Given this list of marker genes MKKS, DIXDC1, PPM1E, YME1L1 (YME1 like 1 ATPase), BUB1, MIR138-1, DRD3, TESK1, HNRNPA2B1 (NCBI Gene Id 3181), SMG5 (SMG5 nonsense mediated mRNA decay factor), SYNPO2, MAP6, CLSTN3, C15orf62, DNM1L, TBC1D13, ODF2, CHMP7, HSP90AA1, PGAM5, CDC6, PLA2G5, CELSR1, KLHL22, ACAA2, KANK4, PLAUR, PPP3CB, TACC3, LILRB2, PRELID1, UPF1, MAP9, LIMCH1, PARL, BORA, SLF2, SRC, PEAK3, CENPV, PKD1, TPR, NBDY, NUF2 (NCBI Gene Id 83540), FGF8, ATRX, BCAS3, TPPP, TMED9, MYCBP2, CEP135 (centrosomal protein 135), GRID2, VPS35, TTK, HUWE1, TMEM39A, BCL2L11, POT1, GCLC, ARF4, MAPK9, TMOD2, CUL7, EML3, NCK1, ATMIN, TBC1D24, SPTA1, SMARCA2, PHF23, ZWINT, ARPC5, EVI5, NEK6, DCTN1, SEC16A (SEC16 homolog A, endoplasmic reticulum export factor), ACTB (actin beta), HAUS1, PDE4DIP, MAVS, ALMS1, WNT4, KAT2A, RAC1, FBXO4, BRD7, GIT1, MIR149, ZDHHC6, INPP5J, WASHC1, PFDN2, SWAP70, TMSB4X, RND3, TTBK2, BID, TAC1, NFRKB, SPECC1L, PTGES3, SMG6, SURF4, SKA3, ANAPC11, SMARCC2, USP7, PHLDB1, EFNA5, CALCOCO2, F11R, CIT, HIP1R, CDC42EP5, MSX1, ARHGAP44, TUBB4A, SETMAR, SDC4, SIRT7, TGFA, MTBP, KNL1, MTCH2, HAUS2, PIKFYVE, PSMA8, CBLN1, ARHGEF15, STX5, CNOT1, NCKAP1L, MTM1, SPTBN1, MAPK1, PRKCQ, SCFD1, CUL9, DAZL, PYCARD, SMC4, CCL26, SLC39A12, MECP2, PAN2, FZD10, CHMP4B, CHEK1, CCT6A (NCBI Gene Id 908), PPM1F, MDM1, NCAPH2, FGFR1, TENM1, KIF9, ARAP2, MAK, CFL2, PARP1, CSF3, HCLS1, TNKS2, NANOS2, MSN, LIG4, CDK2AP2, CDK10 (cyclin dependent kinase 10), ERC2, SPAG5, PISD, XRCC1, CTC1, ODF2L, CAPZA2, SVIL, PIK3R1, HDAC8, SPHK1, RHOC, TFEB, MYO5A, SPC24, SMARCD1, HASPIN, ARAP1, LMOD1, PDCD6IP, TRPM2, LCMT1, DMRT1, SLAIN1, DYRK1A, DVL2, CAPZA1, S100A8, DIAPH3, NCAPD2, CYFIP1, CAPN2, TBC1D9B, ULK1, OPA1, WEE2, SHANK3, RND1, BAIAP2, BIN1, SYT4, FSHR, CLU, GAS2L1 (growth arrest specific 2 like 1), MYOC, MIR214, MCOLN1, JAM3, ZMYND10, NRP1, ESAM, KATNB1, CHMP1B, ARL2, ACTR5, CORO1A, CYLD, WASHC2A, MOS, CEP97, ARHGEF10, SPAST, PLK4, EHMT2, BMERB1, AURKA, SMARCB1, BBOF1, PIF1, GAS2L2, OBSL1, LATS1, ARPC3, LRFN1, PXN, FCHSD1, PJVK, YY1, NSMCE3, KCTD17, CDK5R1, SIGLEC15, LRFN4, NCK2, ANXA2, CCT8, PRKN, WRAP73, TERF1, BCL7A, BRAF, GNAI1, ARF1, CAMSAP1, TMEM14A (transmembrane protein 14A), PSRC1, GPR143, RBSN, MGARP, SIRT6 (NCBI Gene Id 51548), TBC1D17, RHOD (NCBI Gene Id 29984), PRMT6, NUMA1, IER3, SIRT2, SNX4, ARHGAP28, DYNC1H1, SAR1B, OCLN, CLEC16A, GAP43, MAPK15, PRKCD, RAPGEF3, SSH1, IQCJ-SCHIP1, MAP4, VASP, RALA, ARHGEF19, PKIB (NCBI Gene Id 5570), LIMK2, CCT2, BAG4, SFPQ, BRK1, CEP76, TMEM33, CDC42, MAPRE1, CUL3, TFPT, SPTB, ANAPC1, CHMP5, ABL1, RCC1, SPC25, OSBP, CHMP4BP1, CCSAP, NABP2, SPATA4, ARAP3, SDC1, ACTL6B, CLASP1, IRGM, SEPTIN7, TMEFF2, PTK2, SMARCD2, CPLX3, PRDM9, CAPZA3, CTNNB1, ACTL6A, PICK1, SYT11, FBXO5, BBC3, MAPK3, CDCA8, PRKAA2, PRUNE1, NGEF, BRCA1, RAB5A, USP44, TMEM135, STMN3, ANAPC15, GHITM, RUVBL1, ZNRF2, DDHD2, MSTO1 (misato mitochondrial distribution and morphology regulator 1), TEX14, SQSTM1, RBM14, RAB1B, DIAPH1, STMN2, PIN1 (NCBI Gene Id 5300), CCL21, CDKN1B, PLXNB1 (plexin B1), BMP10, TERF2IP, CD2AP, FSCN1, BCL7B, EP300, INO80, APC, RAD51AP1, PINX1, PLK1, SMARCA4, IQGAP2, HAUS8 (NCBI Gene Id 93323), NME7, MIEF2, WDPCP, TOM1, SPTAN1, WAPL, PKMYT1, TBCD, EPHA1, OOEP, TGFB2, ODAD3, SMARCA5, MPHOSPH9, ANAPC5, NCAPG2, TBC1D8, ADD1, CTCF, RGCC, FUZ, SPEF1, CDK5R2, GEN1, ITGB1BP1, HAUS7, EPGN, VILL, CYRIB, MEIOSIN, ATG2A, WRAP53, BUB3, CHMP1A, WASF1, ODAM, NAA20, CAPN10, CDC16, SFRP1, MARK2, TBC1D25, YLPM1, COTL1, PRKAA1, AURKAIP1, MYC, PREB, DYNC1LI1, CCNF, PAN3, CCL24 (NCBI Gene Id 6369), CDCA2, LRRTM2, PML, NSMCE1, DOC2A, PINK1, SMARCC1, BAX, BIRC5, NUBP1, CKAP5, NAV3, SLX1A, ECT2, PHF10, TBC1D10C, INCENP, HSF1, BICD1, TMEM102, SMC5, NAT10, ATM, STN1, CDKL1, PAFAH1B1, SYT5 (synaptotagmin 5), SAR1A, RMI2, BMP7, CENATAC, FLNA, ARF6, VAT1, SHCBP1L, BNIP3, NEK2, OR2A4, NOL3, ATG12, TEN1, SIRT1, CCDC88A, TRIM27, FES, RAB7A, INF2, MAP3K20, TOM1L2, CLTC, PID1, ARHGEF10L, SCARB2, CCT3, SNX18, WASF3, VPS4B, STAU2, RHPN1, SLC9A1, CCP110, SHANK1, MOAP1, GSK3B, STAT2, ADD2, ROCK1, SEC22B, EVI5L (ecotropic viral integration site 5 like), TNF, EML2, CORO2B, SMPD3, ZW10, SLC2A4, WNT5A, SYNPO, ATP5IF1 (ATP synthase inhibitory factor subunit 1), TBC1D10B, WDR1, ABI2, TBC1D5, CPLX2, BCL7C, MMP9 (NCBI Gene Id 4318), XRCC5, CPLANE2 (NCBI Gene Id 79363), PLEK, ASB2, PIP4K2B, ENDOG, UBQLN4, BCL2L1, KATNBL1, RPH3AL, ANKRD53, WDR47, CDC23 (NCBI Gene Id 8697), SYNPO2L, TACSTD2, SKA2, RPS3, HDAC6, RHOBTB2, CD47, NF2, LUZP1, USP6NL (USP6 N-terminal like), SLC25A6, DVL3, BST1, CTTN, CAPN6, STX18, TBC1D14, CDH5 (cadherin 5), MYLK3, NPM2, MIR1-1, LPAR1, CCT7, RAC2, TP53, HAUS6, HIGD1A, CDK5RAP2, GSK3A, MNS1, SYNJ1, SNCA, CFL1, GPR3, ANXA1 (annexin A1), WASHC5, GPR65, S1PR1, SLC35F6, CAMSAP2, SPDL1, SLC30A9, TPM1 (NCBI Gene Id 7168), RUVBL2, TACR1, PLEKHH2, SNX7, AXIN2, RDX, TBC1D10A, POC1B, GRN (NCBI Gene Id 2896), NSMCE2, NUPR1 (NCBI Gene Id 26471), BAIAP2L2, SEPTIN9, GPX1, EDN1, ACTN2, INS, CDC20, ATXN7, PIP4K2A, STIL, ATG3, RHOA, CAV2, NSMCE4A, TRIM54, SMCR8, MAP2, KANK1, PSMG2, PPP2CA, PTK2B, DZIP1, GMFB, TMOD1, HAUS5, TWF1, IL5, STAM, MARCHF5, NFE2L1, KIF18A, FERMT2, SYT3, TAL1, TRIM32, HRAS, RAE1, EPHA3, INO80B, PRRT2, PHIP, RPH3A (rabphilin 3A), DMTN, CXCL12, CHEK2, STMN1, EPHA5, IK, SEMA5A, PRMT5, STRA8, RAB3A, RABEP2, ANKRD27, CALR, MIEF1, CDK2, CAPZB, RAB3GAP1, S100A10, RAC3, ITGB3, RAD1, INTU, MAPRE3, PLEKHG2, STMN4, CPLX1, NAA80, TMOD4, PBRM1, SAXO1, TAPT1, CCR7, SMIM22, TBC1D3, CNTROB (NCBI Gene Id 116840), ACTG1, BIK, CARMIL1, TGFB1 (transforming growth factor beta 1), HNRNPU, HRK, PSMD10, HAUS4, CEP120, CROCC, MAD1L1, ANAPC2, FNIP1, BAK1, INPP5K, MCIDAS, PLD6, DAAM2, VIL1, IFT140, TNFSF10, S100A9, TSC1, MAPT, CCN2, ARID1A, TOGARAM2, GNL3, EVL, RTEL1, ARHGEF18, MCPH1, INO80D, TFRC, PAK3, TMEM106B, HAX1, ARHGEF16, DCN, KDR, MAP1A, C11orf65, MCRS1, AP1AR, CCDC8, MSX2, CCNB1, MAD2L2, NDC80, KIF20B, NVL, C2CD5, RNF186, LRRC4B, NEXN, BAZ1B, LIMA1, PREX1, GPM6B, GRIK5, SYT9, DCP2, CAPG, BICD2, DLG1, CNOT2, ADCK1, RHOQ, AKAP13, CCT4, CORO1B, MTOR, CEP70, FYCO1, TBC1D7, SSBP1, CNOT6, RNH1, CD28, SMC6, DDHD1, CSF1R, WDR44, PRAP1, SYT13, RAB11FIP3, RPS6KA2, HSPA1B, WASHC4, NEK7, MARK4, ABITRAM, TOM1L1, TCP1, CHMP4C, MID1, BAIAP2L1, TTC8, SMAD4, CDK1, FEZ2, FBXO43, HNRNPD, ARHGAP35, MAP2K2, TBC1D2, SMARCD3, EPS8, SLIT2 (NCBI Gene Id 9353), LRRK2, NAA10, MYO19, ATR, WASH3P, GSN, PRKD1, CHFR, BECN1, IFT20, PLCB1, MAPRE2, TOGARAM1, ARFIP2, RAB33B, SPTBN2, RAB3GAP2, CRIPT, UBE2C, CYRIA, TRPV4, NUP62, PDGFRA, KANK2, SPICE1, KIRREL1, WAS (WASP actin nucleation promoting factor), GBA2, GNL3L, MKI67, GPER1, FSD1, NPHS1, SDCBP, KIF24, TBC1D15, PAK1, CDKL5, TSG101, TRIM36, INO80C, RNF4, TBC1D30, HCK, MTSS1, FIS1, TJP1, BAD, CLIC4, FKBP4, MID1IP1, ARHGEF2, HGF, DLGAP5, VANGL2, LMOD2, CDC42EP3, MIR335, SYNE2 (spectrin repeat containing nuclear envelope protein 2), FGF13, MYO3B, MFF (mitochondrial fission factor), TBC1D20, LRP5 (LDL receptor related protein 5), FCHSD2 (NCBI Gene Id 9873), ZNF205, MPV17L, GRHL3, SPIRE1 (spire type actin nucleation factor 1), RGS4, CKAP2, BMP4 (bone morphogenetic protein 4), CENPE, HNRNPA1, CAV3, CAPRIN1, WASHC3, MTMR3, SPTBN5, PRKCE, CTNNA2 (catenin alpha 2), SDCCAG8, IL1RAP, BTC, CARMIL2, GOLPH3, DCDC2, PRICKLE1, CHMP2A, NCAPH, PPP2CB, TAOK1 (NCBI Gene Id 80214), NAF1, RHOG, SSH3, RICTOR, F2RL1, ARHGEF26, SNX30, LRSAM1, INO80E, TAOK2, SLC25A31, PIWIL2, MARCHF7, WASHC2C, ADAMTS16, ARPC2, ELN, RUBCN, PTGER4, ZNRF1, ARHGAP18, DUSP1, CNOT6L, KAT2B (NCBI Gene Id 8850), UVRAG, PIP4K2C, PAK2, PPIF, DPF3, GRB2, FEZ1, CEP295NL, H3-3B, SLC30A1, FEN1, MAD2L1, MIR21, IFI6, SLC25A4, MLLT11 (MLLT11 transcription factor 7 cofactor), ATAT1, PARN, PTPRS, IL1A, CDH2, CDC42EP4, NEDD9, CHMP3, TBC1D19, NES, MAGEL2, PDXP, KNTC1, TNKS, SLC25A5, FBXW5, ANKRD23, MYO3A, TGFBR1, SGSM3, AKT1, TBC1D16 (TBC1 domain family member 16), TRIM37, PPP1R35, LIMK1, PDGFRB, LNPK, EID3, CDC27, AKAP9, MAP1S, FZR1, RAP1GDS1, CCDC15, AURKB, IGF1, MAD2L1BP, SERPINF2, HNRNPC, EREG, KANK3 (KN motif and ankyrin repeat domains 3), TECPR1, MYADM, PPARG, L3MBTL1, SNX9, MLST8, AVIL, DYNC2LI1, PFN1, SH2B1, ZNF207, TERF2, CARMIL3, TCHP, RHOBTB1, SMARCE1, HECW2, BST2, SMAD3, RND2, MAP6D1, TENT4B, ERCC4, NCAPG, FLCN, ZWILCH, MAP3K4, STYXL1, GMFG, CENPF, ANAPC7, PHLDB2 (pleckstrin homology like domain family B member 2), DPF2, DPF1, UCHL5, CYFIP2, PDGFA, CAMSAP3, WHAMM, MACROH2A1, BMF, TBC1D21 (TBC1 domain family member 21), ARFGEF1, SH3BP1, RHOF, DOC2B, SCIN, ARL6IP1, KAT5, LIF, STMND1, RB1, TBC1D22A, STOX1, GDI2, ENTR1, ADRB2 (NCBI Gene Id 154), PDE2A, DNAI3, RIPOR2, HSPA1A, PFN2, RABGAP1 (NCBI Gene Id 23637), HOXA13, PFN3 (NCBI Gene Id 345456, profilin 3), TMOD3, UBAP2L, SYT8, FXN, BBS4, TBC1D1, ARID1B, ARHGEF5, SYT2, RIOK2, ZEB2 (NCBI Gene Id 9839), TBC1D4, SLAMF1, P2RX7, XRCC3, SYT7, WASF2, HAP1, CPLX4, SLX4, PLK2, RASA1, FAM107A, KIF21A, MAP1B, HTT, CHMP6, DLC1, LMOD3, SYDE1, ATP13A2, PLXNA3, NOTO, SENP6, SLC4A2, ARFIP1 (NCBI Gene Id 27236), CCL11, SKA1 (NCBI Gene Id 220134), WDR45, CGNL1, ERCC1, EPHB2, DHX36, EFNB1, SSH2, PRP4K, RHOT1, C9orf72, ASAP3, DYNLT2B, INSR, CDC42EP2, RAD50, TRAPPC12, CEP295, USP10, MET, XRN1, VPS11, MICU1, GPSM2, UBQLN2, ATG5, TRIOBP, PDGFB, LMNA, CDC42EP1, PDE3A, ELAPOR1, DAPK3, RAD21 (NCBI Gene Id 5885), TRAF3IP1, SMC2, CLASP2, FLII, SASS6, MRE11 (MRE11 homolog, double strand break repair nuclease), CHMP4A, PMAIP1, ARHGEF9, CCT5, ABI3, APOA1, RALB, ABL2, PARP3, ARHGAP40, C10orf90, MIR20A, TRIP13 (NCBI Gene Id 9319), CSF2, ARID2 (NCBI Gene Id 57676), TBC1D22B, TINF2, APC2, MCU, TGFB3, ARHGAP6, PATL2, ACD, STXBP1, HAUS3, FER, MAP2K1, BUB1B, DRG1, WASH6P, TBC1D12, MAP2K7, RP1, CDC25C, BOK, FZD9, SMG1, IL1B, FRMD7, TBC1D2B, PIK3CA, PIK3R2, ARHGAP17, RALBP1, ADD3, ARMH3, LCP1, CRACD, YAP1, RHPN2P1, SH3GLB1, OAZ3, CLN3, WIPI1, SPTBN4, ACTR8, TRIAP1, NEB, TREX1, MAPKAPK5, H3-3A, MUL1, LAPTM4B, DSTN (NCBI Gene Id 11034), CHMP2B, PLSCR3, IFT88, IGF2, CLIP3, MTPN, SORBS3, ARPIN, PNKP, OMA1, CHCHD10, CLIP1, HDGFL3, FAM162A, SYT1, ANK1, CCDC88C, NUSAP1, HRG, AMOT, TWF2 (NCBI Gene Id 11344), SIVA1, UBE2B, CIB1, HORMAD1, NPR2, PPFIA1, ROCK2, ANAPC4, CASKIN1 (NCBI Gene Id 57524), CX3CL1, CRK, ARPC5L, PROX1, INPPL1, RAB11A, EHD3, TMEM67, ARHGEF7, DKC1, NCAPD3, LMAN1, EZR, EDN3, XIRP2, CENPJ, EGF, KLF4, PPP1R10, RHPN2, TMSB4Y, LRP1, WNT3A, NCKAP1, NPM1, TPX2, FHOD1, NBN, EXOSC10, SLAIN2, ALOX15, SLX1B, NME6, RNF5, ESPL1, SLF1, ZMYND8, PTPRD, DDX11, here is a description of the gene set: Human Gene Set: GOBP_REGULATION_OF_ORGANELLE_ORGANIZATION Any process that modulates the frequency, rate or extent of a process involved in the formation, arrangement of constituent parts, or disassembly of an organelle. species: Homo sapiens